The following is a description of a gene set: Mouse genes annotated to increased hepatoma incidence (MP:0010264) retrieved from the Mouse Genome Informatics database via MouseMine studied in species Mus musculus from publication Motenko H, Neuhauser SB, O'Keefe M, Richardson JE (PMID 26092688) Mouse Gene Set: MP_INCREASED_HEPATOMA_INCIDENCE, and this is the list of marker genes: Myc, Fancm (Fanconi anemia, complementation group M), Sav1, Cat, Acox1, Fah, Cdc20, Nf1, Tnk1, Aurka, Dna2, Ccng1, Rbm38, Srpx, Ahr, Socs1, Amy1, Usp44